The following is a description of a gene set: from publication La Manno G, Gyllborg D, Codeluppi S, Nishimura K, Salto C, Zeisel A, Borm LE, Stott SRW, Toledo EM, Villaescusa JC, Lönnerberg P, Ryge J, Barker RA, Arenas E, Linnarsson S (PMID 27716510) Human Gene Set: MANNO_MIDBRAIN_NEUROTYPES_HRGL2C Cell types are named using anatomical and functional mnemonics prefixed by 'm' or'h' to indicate mouse and human respectively: OMTN, oculomotor and trochlear nucleus; Sert, serotonergic; NbM, medial neuroblast; NbDA, neuroblast dopaminergic; DA0-2, dopaminergic neurons; RN, red nucleus; Gaba1-2, GABAergic neurons; mNbL1-2, lateral neuroblasts; NbML1-5, mediolateral neuroblasts; NProg, neuronal progenitor; Prog, progenitor medial floorplate (FPM), lateral floorplate (FPL), midline (M), basal plate (BP); Rgl1-3, radial glia-like cells; Mgl, microglia; Endo, endothelial cells; Peric, pericytes; Epend, ependymal; OPC, oligodendrocyte precursor cells. species: Homo sapiens, and this is the list of marker genes: PREX1, TEKT1, NEK11, PCDH17, CEP126, MT1X, PIEZO2, PEA15, DPF3, GDPD2, RAB9A, CHST3, SMYD3, HES5, KRT17 (NCBI Gene Id 5103), SLC7A11, SMOC1, RIT2, CD44, DHFR, MAP3K1, BIRC5, NDRG2, RPE65, CCDC39, ATP1B2, MGST1, GNG7, CDH13, TGFB2-OT1, DNAH6, SLITRK2, MYLK, ITPR2, RAB13, BCAN, GPM6A, HBG1, FOXL2, KCNIP1, MDGA2, CREB5, ILDR2, LRP1, CHST6, DNAH7, SPRY1, ARC, LITAF, TMBIM1, CFAP44, MRC2, PHGDH (NCBI Gene Id 94672), SERPINE2, TNFRSF1A, NFIX, IGFBP2, ADGRG1, CA12, GINS1, TMEM255A (NCBI Gene Id 55026), LIMA1, F3, KAT2B, IER3IP1, WFDC1, MYORG, TSC22D4, ATP1B1, CSGALNACT1, ZWINT, GRIA1 (NCBI Gene Id 2890), RASSF2, C6orf118, KCNJ1, WSCD1, USP2-AS1, CENPN, EDNRB, EPCIP, EGLN3, IRX1, PDPN, PMP2, KCND2, SHISA3, GMPR, ATP2B2, OMG, SOX2-OT, SH3D19, PDE7B, IGSF9B, TRIB2, SCHIP1, ITGB5, ACSS1, DNER, IFI44L, SPRED1, AFF1, SCUBE2, MPC1, SKA3, COL27A1, HEPACAM, HEPN1, CDCA5, SCAMP2, PBK, FUT9, SEC14L2, OPCML, PLTP, PMP22, THSD4, NCDN, SLC6A9, ADGRB3, PACRG, INKA2, JPH3, COL9A3, NRXN1, TIMP4, FAM81A, GATM, HBA2, ITPKB, RFC3, SLC1A3 (solute carrier family 1 member 3), CCDC8, SDC3, ANOS1, HRH1, ARHGEF4, LRRC4B (NCBI Gene Id 94030), LRATD2, FOXM1, HAS2, RAVER1, NPNT, TNC, PDE1C, TAGLN2, DPP7, DOCK1, LIX1, NCAN, MORN5, NDP, ABHD17A (abhydrolase domain containing 17A, depalmitoylase), SOX2, GRM5, FABP7, NOTCH1, MAPK14, LRFN5, GLTP, PKMYT1, HBG2, LRIG1 (leucine rich repeats and immunoglobulin like domains 1), ETV4, MT3, SLC1A2, ERF, ADGRB1, DCLK1, ITGAV, LUZP2, SLC6A1, DBI, ALDH9A1, SGO2, TRIM67, CST3, ITGB8, SCN1A, DPP6, PLPP3, ETV5, FGFBP3, HOATZ, PON2, ATP13A4, ARHGAP42, CYP26B1, ADCYAP1R1, SLC25A18, PTPRT, KCNQ2, SPEF1, ACSL6, MIR9-1HG, GRID2, EEPD1 (endonuclease/exonuclease/phosphatase family domain containing 1), PCDHGC4, RACGAP1, LFNG, EGR1, PDLIM3, MYBL2, METRN, ACBD7, MCM5, NFIA, EGFR, VWA3A, EPHA3, SPRY4, SLC4A4, SNORD27, ELN, PIK3CB, CSMD3, SOX9, C22orf15, KLRC2, DNAAF3, OPRM1, NEK6, C21orf58, KCNE5, PTN (pleiotrophin), RELN, LMCD1, C1orf21, LAMA1, ANXA5, PRKCA, CENPK, LRRC17 (NCBI Gene Id 10234), CENPF, IQCA1, ADAMTS6, HES1, SPMIP6, TTYH1, PLAT (plasminogen activator, tissue type), PNOC, APBA1, PCDH7, NES, KANK1, ETV1, RHOJ, NLGN4Y, C2orf72, VXN, TMEM232, SPARCL1 (SPARC like 1), HTRA1, PI15, ARHGEF6, FAM89A, MNS1, PTPRZ1, SCG3, NKAIN4, MT2A, DTNA, EFHD2, FABP5, NSRP1, SCRG1, PLEKHH2, LHFPL3, CTNNA3, ZNF474, DCLK2, GABBR2, LYPD1, FANCB, SOX8, OLIG2, AQP4 (aquaporin 4), PSAT1, GPM6B, HBA1, PTCH1, NFATC2, RAB31, PLLP, UHRF1, HAPLN3, COL2A1, CHKA, SCD5, GRAMD1C, ARAP2, NOL7 (NCBI Gene Id 51406), FANCI, NAV1, QKI, ERBB3, ADAMTS3, GRM3, CSMD2, GRIP2, CRTAP, LAMB2, LIFR (LIF receptor subunit alpha), PTPRE, CTNND2, NUSAP1, CSPG5, GNG12, LRP1B, DHX32, NKX2-2, FGFR3, FBLN2, OSBPL6, CD82, CSMD1, SPRY2, SOX9-AS1, SPAG17 (NCBI Gene Id 200162), THUMPD2, CPNE5, MLC1, FAM181B, TAOK3, TMT1A, SPATA6